Given this list of marker genes Gnai1, Gng10, Gngt2, Gnb2, Plcb3 (NCBI Gene Id 18797), Camkk1, Gng5, Camkk2, Adcy5, Prkcg, Cdk5, Oprm1, Gna14, Adcy7, Gng4, Gng7, Pde1b (NCBI Gene Id 18574), Ppp1ca, Pomc, Gnb5, Gng8, Adcy8, Gng3, Gngt1, Gnb3, Ppp2r1b, Pde1c, Prkacb (protein kinase, cAMP dependent, catalytic, beta), Prkca, Ppp2r5d, Prkaca, Prkar2b, Gng11, Prkar1b, Calm1, Gnat3, here is a description of the gene set: Reactome Pathway: Opioid Signalling part of: G alpha (i) signalling events This event has been computationally inferred from an event that has been demonstrated in another species.<p>The inference is based on the homology mapping from PANTHER. Briefly, reactions for which all involved PhysicalEntities (in input, output and catalyst) have a mapped orthologue/paralogue (for complexes at least 75% of components must have a mapping) are inferred to the other species. studied in species Mus musculus electronically inferred by orthology from the curated human pathway